The following is a description of a gene set: Genes predicted to be targets of miRBase v22 microRNA hsa-miR-520d-5p in miRDB v6.0 with MirTarget v4 prediction scores > 80 (high confidence targets). Human Gene Set: MIR520D_5P studied in species Homo sapiens from publication Chen Y, Wang X (PMID 31504780), and this is the list of marker genes: NAA50, MTSS1, ATP2B2, RAP1B, SCAMP5, ITPR1 (NCBI Gene Id 619543), MINPP1, CREB1, CCT7, DKK2, SFPQ, CPNE2, DIP2A, NUP205, SCN8A, ZMYM1, EFEMP1, SUB1, RBBP5, SLIT2, GPATCH2L, HNRNPDL, MAPK1IP1L, MAP4K3, WASHC4, LTN1, HOOK3 (hook microtubule tethering protein 3), ADAMTSL3, CAMK4, PCDH9, TMEM33, CEP120, MATCAP2, PER2, EFR3A (NCBI Gene Id 23167), UBR1, THOC3, PTX3, GPT2, GRM7, LATS1, MPRIP, FBXO45, ZNF461, L3HYPDH, APPBP2, HMGA2, ITM2C, BCL11B, ZNF106, ACBD5, IFT70B, APBA1, AGRN, ADAM10, TAFA1, GRIN3A, MITF, TTBK2, LRRC40, RSBN1L, FAM3C, NSG1, SLC16A4, LSM8, SOS1, ASH1L, TBR1, SMC3, USF3, RUFY2, SMURF1, PRIM2, FGFR2, CREM, PPFIA1, UBA6, YWHAQ, SERPINB8, MLLT6 (MLLT6, PHD finger containing), MAPK1 (NCBI Gene Id 5594), TMEM163 (transmembrane protein 163), NANOS1, JAG1, OAT, SGK3, ZFP36L1, PKDCC, INTS10, DCAF7, TMEM50A, VANGL1, GOLGA6L4, PTPRG, VSIG10, ZNRF3, EP400, ATP8A1 (NCBI Gene Id 10396), ATP1A1, TLE4, NPAT, SLITRK6, KIF1B, LHX6, PAFAH1B1, SRSF2, SLC10A4, NUP37, PDE4B, NDUFS1, MTMR12, EGR1, SIRT1, BDH2, ARGLU1, ARHGAP35, SLC38A2, MRS2, YBX1, SCEL, SLC6A6, APPL2, ELAVL2, MAST4, DNTTIP1, SPRED1, PHIP, AKIRIN1 (akirin 1), ANO8, PLAGL1, TAF12, AGFG1, ZBTB34, SC5D, ARPP19, LUC7L2, HEG1, ZNF655, WNK1, TMEM39B, SLC25A12, SERPINB1, MTM1, TRDN (triadin), KLHL28, E2F8, IRX2, ROR1, SGK1, MYRFL, NR2F1, PARP11, CTTNBP2, MXD1, GATAD1, LRRTM3, HIP1, MYRF, GLI3, PRKCB, ZCRB1, ATXN1, SCN3A, FAM221A, SLITRK4, WDR43, SPATA13, ZEB2, CDH4, TBCCD1, ARHGAP12, SELENOS, UBR5, ZNF516, HLCS, KPNA1, EPC1, MIS18BP1, QKI, DNAJC6, NEXMIF, MECOM, FZD3, RRAS2, CERT1, HYCC2, FOXJ3, BHLHE40, PELI2, BTAF1, RBFOX1, MAPK8, RSBN1, BNIP2, IQGAP2, RP2, CALB1, MEAF6, OGA, RAI14, VGLL3, PCGF3, UBE2D3, LRP5, GPR63, ARFGEF3, DRAM1, LRBA, FBXO30, EOMES, OLFM1, CNTN1, PUM1, MIPOL1, TSNAX, CERS6, MEOX2, EGFL6, LARP1, RAB14, TSC22D2, UBE2B, PLEKHF2, CSMD1, HEY2, CRTC1, PALS2, BRD4, EPHA3, TNFRSF19, ZMYND19, KLF4, TXNIP, B4GALT1, UBN2, CDH15, EDIL3, GTF3C3, HIRA, DENND5B, CNTN5, PNN, FBLN2, NFIA, PSPC1, DIP2C, BZW1, CDC42, ASB13 (ankyrin repeat and SOCS box containing 13), PEX5, MBNL1, SEC24B, TMTC3, BUB1B (NCBI Gene Id 701), SLITRK2, DDHD1, MIB1, PTPRE, GOLGA6A, PRPF40A, KPNA4 (karyopherin subunit alpha 4), AASDHPPT, HSD17B13, DOCK4, SEC14L2, SMIM43, CLSTN1, PRKD3, GNPTAB, ITGA10, HOXC8, PARP8, FAM169A, ANKRD44, PIP5K1A, OPA1, SIAH1, NUFIP1, CLLU1-AS1, ADCYAP1, CYP7B1, TAF8, TLCD4, LMNB1, NBEA, IRAK2, PPP1R9A, MLLT10 (NCBI Gene Id 8028), NXT2, RPS6KB1, KLHL7, CBX3, GOLGA8A, BRINP1, SEH1L, GLS, ARL5B (NCBI Gene Id 221079), GOLM2, KDM5A, GOLGA8T, PTPN12, BRD3, FKBP14, H1-0, TMF1, PPP3CA, HS3ST3A1, PEX3, PSD3, DENND2B, EPCAM, NUP43, PPM1A, SYF2, ZNF827, PCGF6, RPRD1A, ZC3H12D, ROBO1, MYOF, PLAGL2, CPEB2, MEIOC, RCAN2, RNF182 (ring finger protein 182), DLX4 (distal-less homeobox 4), NWD2, ACTR3B, C8orf44-SGK3, CNTNAP3, RAP2C, SCN2A, SMPX, C1D, CNOT2, ACER2, DDX17, PKN2, TMEM196, GOLGA8N, DLX1, RORA, HECTD1, MAEL, RBM12, DOCK10, C1QTNF7, TSHZ1, CDYL2, ARVCF, SELENOI, STK26, CPEB3, RNF216, SLC39A14, GSPT1, CNKSR2, SMAD2, SLC35D1, API5, CASP7, CEP128 (centrosomal protein 128), TET2, PBX1, USP54, CD1A, CNR1, HEY1, COL4A1, THSD7A (NCBI Gene Id 23249), VAMP4, GOLGA6D, TMX4, NEGR1, PELI1, ZNF772, ECT2, COL3A1, ADIPOR1, VAV3, TAB2, TFDP2, MAMLD1, TTN, NFATC3 (NCBI Gene Id 82543), HNF1B, EPHA7, PFKFB3, MEOX1, EPHA1, HYCC1, KIF5A, NOVA1, DUSP6, BTBD7, FOXO1, SV2A, AMFR, OSTM1, TOM1L1 (NCBI Gene Id 10040), SAFB, RBM23, WDFY3, PPP5C, SKIL, PMS1, RHOT1, BMP3, TRAPPC8, FAM181A (NCBI Gene Id 90050), IRF2, TFRC, FAM184A, RSRC2, GJB2, RSPH4A, HMGB3, FRMD6, ACSL4, ATAD2B, TMEM161B (NCBI Gene Id 153396), CHN2, RIF1, CREBRF, L3MBTL3, USP27X, TWIST1, CETN3, HIPK1, SUMO1, BOD1L1, BEND4, RFC1, CTHRC1, TRAPPC13, RAB12, IRAK3, GABPA, DDX6, SERINC5, KCNK2, RGS7BP, TSHZ2, SPCS3, ELF1, IGSF3, WWC2, RBM26, FCGR2A, STXBP4, GATAD2B (GATA zinc finger domain containing 2B), TTC28, RAP1GDS1, ADARB2, FAM76A (NCBI Gene Id 199870), MMGT1, LIPA, GPBP1, UBA3, SORT1, USP49, GORASP2, PTPRA, HNRNPH1, UBE2E3, CEP57, ANKRA2, SMARCA2, LEF1, ARHGEF33, TXNDC9, SERF2, YY1, CCDC6, ZMYND8, TOX, CAV2, IFT52, TMEM170A, RNF217, TES, TBL1X, UBE2Q2, HNRNPU, SCAI, PKIA, SESTD1, NHS, GALNT7, SLC34A2, EBF2, GIPC2, PDE10A, PRNP, DOCK1, CLVS2, RBM39, TMEM181, SGMS1, TRIO, TRIM23, HS3ST1, GOLGA8J, PPM1L, ACKR4, AR, SH3BGRL2, EIF4E, APC, C1QTNF3, SMC4, FAM83B, GFPT1, JMY, PNISR, ZMYND11, CD47, DIRAS2, GMFB, DYRK1A, SPTSSA, AHCTF1, RALGPS2, CACNA2D1, BCOR, PPFIA3, OLIG2, RNF130, NUDT4, IGSF11 (NCBI Gene Id 152404), SMAD3, CACNA1D, MTTP, LARP4, MBTPS1, PTH2R, PPP1R8, LIN9, TMEM170B, SLC22A10, BMPR1A (NCBI Gene Id 8035), PROX1, TAFA2, PRKAB1, TM4SF4, CYTH2, COX16, EED, EID1, CDC42BPB, ANKRD46, DLG2, TEAD1, TRPS1, EGLN1, ATF2, SRBD1, RPS6KA3, SOX5, GOLGA8Q, TTC9, TRA2A, CACNA2D2, ZNF704, PTHLH (NCBI Gene Id 5744), MYF6, ST18, CNOT6L, MAPK6, SLC17A6, TPTEP2-CSNK1E, TCP11L2, MAGEB6, PPP1R21, CACNB2, SLC4A7, CRHBP, PDZRN4, CCN1, CCNT2, RAB6B, PSG1, GIGYF2, ETS2, FBN1, VIRMA, RAB11B, CEBPD, SFSWAP, GNB4, SLC1A2, TCEAL1, CHAMP1, USP7, CAMTA1, AKAP11, HNRNPK, ZWILCH, GDF10, PCDHB2, SP8, CDH19, ADAMTS16, FZD2, MSRB3, CGGBP1, ZBTB7C, PCBP2, ZFR, SS18, WIPF1, LAMC1, USP31, NFYB, PTPRS, ARHGAP29, FCHO2, LRP12, ITGB8, NR4A2, GOLGA6B (golgin A6 family member B), PDIK1L, KIF21A, ESYT2, SESN1, COL1A2, GTF2A1, RBM27, CLNS1A, LYPD6, PREX2, CHIC1, ADAMTS5, DCUN1D1, SMURF2, POC5, CD46, SIPA1L2, TNKS2, KCNC2, TMEM30B, TCF4, ATG2B, PTPRB, HS3ST3B1, KAT2B, RNF220, NRK, ZFC3H1, BDNF, FIBIN, PUS7, RGCC, DCX, ADAM23, PHLDB2, NKRF, ARL13B, TMEM30A, CHODL, ZNF367, HDAC2, HIVEP2, GPC6, IL12B, PALLD, C17orf75, INTS6, ATAD5, CSMD3, CDC25C, RANBP9, ZSWIM4, FBXO3, TMEM215, GNAI3, ARIH1, PAPOLG, TENT4B, SECISBP2L, EML6, LMAN1, SRSF10, AZI2, GPM6A, GPR180, ACTA1, MEGF9, DACH1, RAB33B, TCF7L2, TFEC, CCSER1, EPB41 (NCBI Gene Id 2035), RAB11A, ZMYM2, DCAF4L2, C11orf58, CADM2, REST, PLPP3, OXSR1, SRD5A1, COL11A1, ZBTB44, FAM13C, EGR4 (NCBI Gene Id 82930, early growth response 4), TFAP4, PPP1R1B, SULF1, IKZF2, SMCHD1, GRID2, STAU1, KIF2A, ACSL3 (NCBI Gene Id 55484), SSB, PRKRA, MED4, TXNL4B (thioredoxin like 4B), ATP2B1, NXPH2, COX18, G3BP2, RBL1, JARID2, UGDH, TMEM220, ZMAT3, HOXA3, APLN, ENPP4, SIX4, VCAN, ZFP36, FAM76B, C11orf54, PHF20L1, CIAO2A, PLEKHG1, HADHB, WIPF3, PSMB9, SH3KBP1, ADK (adenosine kinase), KIN, MSS51, ZIC3, NEBL, NLGN4Y, ACTBL2, LRP1B, RNF138, CLK4, PRELID3B, FBXO32, DCAF10, KDM6A, MYOD1, SP4, SEPSECS, TGFB3, GOLGA8H, HSPA1B, CYP20A1, FOXD3, MEF2C, STRBP (spermatid perinuclear RNA binding protein), ERBIN, SBF2, ATG16L2, TANK, SYNJ2BP-COX16, LNX2, AP2B1, EBF3, KCNN4, GNA13, SELENOF, VPS13D, SMARCAD1, EEIG2, KMT2C, JUN, E2F3, PTPN13, SOX8, TCEA1, CLOCK, GBX2, SP3 (Sp3 transcription factor), PPP3R1, POLR3B, IMPA1, USP25, PNOC, ASB5, BSDC1, CNOT8, PNRC1 (proline rich nuclear receptor coactivator 1), PHLDB1, SSNA1, IPMK, CDPF1, MBD2, LRRC58, HSF2, UNC5C, TMEM17, SUZ12, PRPF39, CDH9 (NCBI Gene Id 51180), SMNDC1, PAK5, CSDE1, TUBB2B, RYR2, CSNK1E (NCBI Gene Id 1454), SPTY2D1, SLC25A13, FKBP7, GLUD1, STK10, HEPACAM, ADGRL2, ZNF711, JAZF1, EPHA5, CASTOR2, LRRC3B, PDCD10, CENPC, MOK, PLPPR4, ACKR3, CNRIP1, FAM131A, NOP58, GOLGA6C, PSIP1, ZNF638, NAV3, ZYG11B, MOSPD2, GART, DDAH1, NCOA1, MAP4K5, KLF6, SORL1, STXBP5, MAP3K8, HCFC2, JAG2, INIP, SEC24A, ATMIN, GOLGA6L10, ABRACL, PUM2, GOLGA8M, ELOA (NCBI Gene Id 6924), EYA1, TAF4, YTHDC2, BCLAF1, AJAP1, PLCB1 (phospholipase C beta 1), DICER1, TMED7, CDK6, PTPRU, VDR, GOLGA8B, C1orf35 (chromosome 1 open reading frame 35), PPTC7, GLRB, DMXL1, LRP8, CILK1, USP53, SCYL2, UNC13C, CPPED1, INO80D, MPDZ, SULF2, SOCS6, RIN2, ANGPTL7, CEP350, CALU, GID8, KAT6A, SLC30A6, TAL1, DHX40, SOX9, ARHGAP33, KLHL23, TRIP11, SYT4, DLG5, HOXB7, CDK2, METTL9, SLC30A4, SGIP1, ELAPOR1, LATS2, ZMIZ1, SIPA1L1, ID4, GOLGA8R, ZBTB43, SLC40A1, ELK4, TJP1, SHISA3, AZIN2, MGAT3, CWC25, LTA4H, STAT4 (signal transducer and activator of transcription 4), MSR1, IL1A, ZNF583 (zinc finger protein 583), DGKE, MAP3K5, TTK, PRICKLE2, NKTR, DACT3, UBASH3B, PRDX3, PPP6C, ZNF716, TAOK1, PGRMC1 (NCBI Gene Id 10857)